Given this list of marker genes STX3, PPARG, GPR31, ALOX5AP, OXER1, S100A9, S100A8, TMEM175, here is a description of the gene set: Binding to icosanoids, any C20 polyunsaturated fatty acids or their derivatives, including the leukotrienes and the prostanoids. Human Gene Set: GOMF_ICOSANOID_BINDING studied in species Homo sapiens